The following is a description of a gene set: The process in which the cochlea is generated and organized. Mouse Gene Set: GOBP_COCHLEA_MORPHOGENESIS species: Mus musculus, and this is the list of marker genes: Sox9, Fzd2, Dvl3, Wnt5a, Pax2, Ptk7, Grhl3, Six1, Neurog1, Pou3f4, Gli2, Tbx1, Tbx18 (NCBI Gene Id 76365), Tbx2, Tifab, Cthrc1, Myo3b, Nectin3 (nectin cell adhesion molecule 3), Rac1, Tshr, Dvl2, Hpn, Nectin1 (nectin cell adhesion molecule 1), Frzb, Zeb1, Myo3a, Dvl1, Hoxa1, Vangl2, Eya1